Given this list of marker genes SLC22A2, SLC22A3, ABCG2, ABCB1, SLC22A1, here is a description of the gene set: species: Homo sapiens part of: Abacavir ADME Cytosolic levels of abacavir are determined by the balance of its facilitated diffusion into the cell mediated by organic cation transporters SLC22A1, 2, and 3, and its ATP-dependent efflux from cells mediated by ABCG2 and ABCB1. Reactome Pathway: Abacavir transmembrane transport